The following is a description of a gene set: Reactome Pathway: Activation of the pre-replicative complex In S. cerevisiae, two ORC subunits, Orc1 and Orc5, both bind ATP, and Orc1 in addition has ATPase activity. Both ATP binding and ATP hydrolysis appear to be essential functions in vivo. ATP binding by Orc1 is unaffected by the association of ORC with origin DNA (ARS) sequences, but ATP hydrolysis is ARS-dependent, being suppressed by associated double-stranded DNA and stimulated by associated single-stranded DNA. These data are consistent with the hypothesis that ORC functions as an ATPase switch, hydrolyzing bound ATP and changing state as DNA unwinds at the origin immediately before replication. It is attractive to speculate that ORC likewise functions as a switch as human pre-replicative complexes are activated, but human Orc proteins are not well enough characterized to allow the model to be critically tested. mRNAs encoding human orthologs of all six Orc proteins have been cloned, and ATP-binding amino acid sequence motifs have been identified in Orc1, Orc4, and Orc5. Interactions among proteins expressed from the cloned genes have been characterized, but the ATP-binding and hydrolyzing properties of these proteins and complexes of them have not been determined. part of: DNA Replication Pre-Initiation; G1/S Transition studied in species Homo sapiens, and this is the list of marker genes: POLE2, RPA4, GMNN, ORC1, DBF4, POLE3, RPA3, ORC3, CDC6, POLE, ORC6, MCM2, MCM8, POLA1, ORC5, PRIM1, MCM6, RPA2, MCM4, ORC4, CDC7, MCM5, CDT1, POLE4, ORC2, RPA1, MCM10, MCM7, CDC45, PRIM2, CDK2, POLA2, MCM3